Given this list of marker genes LRP5, TRABD2A, SFRP1, SFRP4, ROR1, FZD8, APCDD1L, WLS, FZD6, FZD10, FRZB, RYK, SFRP2, FZD3, PORCN, SFRP5, ROR2, RECK, FZD2, LRP6, FZD7, FZD1, FZD4 (NCBI Gene Id 8322), CTHRC1, WIF1, MUSK, FZD9, TRABD2B, PTPRO, APCDD1, FZD5, here is a description of the gene set: Human Gene Set: GOMF_WNT_PROTEIN_BINDING Binding to a Wnt-protein, a secreted growth factor involved in signaling. studied in species Homo sapiens